Given this list of marker genes CAMK2A, CAMK2B, RPS6KA2, HRAS, DLG2, NRAS, KRAS, MAPK3, CAMK2D, ACTN2, GRIN2B, DLG1, DLG3, RPS6KA1, PDPK1, NEFL, RASGRF2, CREB1, RASGRF1, RPS6KA6, GRIN1, GRIN2D, LRRC7, CAMK2G (NCBI Gene Id 818), MAPK1, DLG4, RPS6KA3, CALM1, here is a description of the gene set: CREB1 phosphorylation through NMDA receptor-mediated activation of RAS signaling studied in species Homo sapiens Human Gene Set: REACTOME_CREB1_PHOSPHORYLATION_THROUGH_NMDA_RECEPTOR_MEDIATED_ACTIVATION_OF_RAS_SIGNALING